The following is a description of a gene set: species: Mus musculus Any process that maintains the redox environment of a cell or compartment within a cell. Mouse Gene Set: GOBP_CELL_REDOX_HOMEOSTASIS, and this is the list of marker genes: Prdx3, Gpx1, Selenot, Prdx1, Txnrd1, Chd6, Egln2, Txn2, Gimap6, Krit1, Apex1, Slc2a10, Txn1, Prdx2, Nqo1, Il6, Git1, Gsr, Prdx5 (NCBI Gene Id 54683), Glrx3, Selenos, Txnrd2, Prdx6, Gclc (glutamate-cysteine ligase, catalytic subunit), Ddit3, Selenon, Ero1a, Nnt, Ero1b, Prdx6b, Nfe2l1, Txnrd3, Prdx4, Nfe2l2